Given this list of marker genes NFKB1, FBXW11, MAP3K8, MAP2K4, UBA52 (ubiquitin A-52 residue ribosomal protein fusion product 1), MAP2K1, CHUK, UBB, TNIP2, BTRC, IKBKG, UBC, RPS27A, IKBKB, SKP1, CUL1, here is a description of the gene set: MAP3K8 (TPL2)-dependent MAPK1/3 activation Human Gene Set: REACTOME_MAP3K8_TPL2_DEPENDENT_MAPK1_3_ACTIVATION species: Homo sapiens